Given this list of marker genes Msra, Glrx, Clic3, Msrb3, Txn2, Ifi30, Msrb2, Pdia3, Txndc12, Dnajc10, Msrb1, here is a description of the gene set: studied in species Mus musculus Catalysis of an oxidation-reduction (redox) reaction in which a sulfur-containing group acts as a hydrogen or electron donor and reduces disulfide. Mouse Gene Set: GOMF_OXIDOREDUCTASE_ACTIVITY_ACTING_ON_A_SULFUR_GROUP_OF_DONORS_DISULFIDE_AS_ACCEPTOR